Given this list of marker genes TCN2, CD320, here is a description of the gene set: studied in species Homo sapiens part of: Defects in cobalamin (B12) metabolism Defects in CD320 cause methylmalonic aciduria type TCblR (MMATC aka methylmalonic aciduria; MIM:613646) resulting in elevated methylmalonic acid (MMA) and homocysteine (HCYS) in newborns. Reactome Pathway: Defective CD320 causes MMATC